Given this list of marker genes Nup210, Nup93, Nup155, Nup58, Seh1l, Aaas, Ndc1, Nup205, Rae1 (NCBI Gene Id 66679), Nup133, Gckr, Nup42, Nup85, Nup54, here is a description of the gene set: part of: Glycolysis Reactome Pathway: Regulation of Glucokinase by Glucokinase Regulatory Protein electronically inferred by orthology from the curated human pathway studied in species Mus musculus This event has been computationally inferred from an event that has been demonstrated in another species.<p>The inference is based on the homology mapping from PANTHER. Briefly, reactions for which all involved PhysicalEntities (in input, output and catalyst) have a mapped orthologue/paralogue (for complexes at least 75% of components must have a mapping) are inferred to the other species.